The following is a description of a gene set: studied in species Mus musculus Any process that modulates the frequency, rate or extent of cell-cell adhesion mediated by cadherin. Mouse Gene Set: GOBP_REGULATION_OF_CELL_CELL_ADHESION_MEDIATED_BY_CADHERIN, and this is the list of marker genes: Ppm1f, Bmp6, Notch4, Mad2l2, Adam19, Dennd6a (NCBI Gene Id 211922), Wnt5a, Smad7, Afdn, Vegfa, Nexmif, Flot1, Ptpru, Notch1, Tjp1, Wnt3a, Tgfb1, Rgcc, Epcam